The following is a description of a gene set: Genes having at least one occurrence of the motif NGGCTCYATCAYC in the regions spanning 4 kb centered on their transcription starting sites. This matches the transcription factor binding site V$ZID_01 (v7.4 TRANSFAC). studied in species Homo sapiens Human Gene Set: ZID_01, and this is the list of marker genes: PAMR1, ERF, CCDC85B, TRIML2, ZNF654, CNTN1, MBNL1, PRR34, FASTK, MIR17HG, PPP2R2B, PKIB, CAPNS1, SART3, MSTN, SERINC1, ITPR3, PLAG1, SMTNL2, RAPGEFL1, TMEM255A (NCBI Gene Id 55026, transmembrane protein 255A), TMEM145, HCN4, ATP2A2, SP4 (Sp4 transcription factor), MTMR11 (NCBI Gene Id 10903), UST, FAU, LRATD1, MEOX1, PTCHD1, TLX3, ZNF668, LRRC49, PLXNA3, NFYA, BCS1L, PA2G4, TP53BP1, TIAM1, PHLPP1, DOK7, MARCKS, MYO10, HMGB1, CNTLN, HOXA3, PLA2G2F, EVA1B (NCBI Gene Id 55194), PCF11, PGF, ERBB3, PSD, GDPD3, XK, SERPINI1, MYH6, PAFAH1B1, ISL1, PAX6 (paired box 6), ZCCHC14, FGFR1, APEX2, NT5C1B, ARHGAP44, GNL3LP1, SEMA6C, UBE2Z, AMOTL1, THAP10, COMMD10, TRAPPC3, FBXO24, PHTF1, SETBP1 (SET binding protein 1), HTR1B, ZNF287, SIAH1, NUFIP2, FBXL3, PAPPA, NGFR, DMD, SLC17A3, TPGS2, ZIC1, ATXN7L2, TAOK2, SUPT6H, TSC22D4, CCNYL1, RPS6KA4, TCF4 (transcription factor 4), PSMD8, HNRNPUL1, CMTM5, CEP95, ZKSCAN8, ADAM12, LRCH4, TNKS1BP1, FOXP1, MRPL49, SCRT2, BPIFB6, MECP2, POLG, TMUB1, RIN2, SECISBP2L, MTF1, KDM6A, ZNF513, CERS1, MPZL2, BICDL1, CCDC121, MSI2, ELK3, DHX30, H3C4, RBM26, GALNT17, MANEAL, ACTN3 (actinin alpha 3), CDK5R1, PLEKHA8, NELL2, SUPT16H, KCNE5, THSD4, CIPC, ZBTB33, TUG1, ACVR2A, WHRN, IRF2BPL, ZNF711, LBX1, SAT1, GABARAPL2, GGN, TSC22D3, MPP3 (NCBI Gene Id 4356), TPRN, NEURL1 (NCBI Gene Id 9148, neuralized E3 ubiquitin protein ligase 1), NLGN3, RNH1, GDF1, BCAM, STX1B, MACO1, SPAG8, AFF4, GPHB5, LIN28A, TRIM46, DNAJB5, DDR2, PRMT3, ODF2, ABTB2, ANXA9, DDX5, RAB2A, RBM15B, GFI1, THPO, H2BC7, C1QTNF6, HOXB9, RB1CC1 (NCBI Gene Id 9821), DCHS1, CHD4, DRG1, TMEFF1, H2AC7, CLEC4D, CDKL5, JMJD1C, PRELP, C12orf54 (NCBI Gene Id 121273), XIRP1, FAM83H, PIANP, MAB21L1, GRIK3, OARD1, CBLN4, CHCT1 (CHD1 helical C-terminal domain containing 1), BTK, DPF3, UBE2N, PLP1, ZIC4, MEIS2 (Meis homeobox 2), CACNG2, CTCF, EPB41, ZNF646, MRPL24, THBS1, GCNT3, SMDT1, MRPL40, FKBP14, HOXB8, PHF8, PRSS36, OTUD7B, ESRRG, ENPP1, KCNK10, TLN1, HR, KRTCAP2, ISCU, SLC35A1, TLX1, ANAPC15, BEND6, SKIL, ADSS2, PHOSPHO1, PNCK, RSKR, DCLK1, DACH1, SNW1, CHRD, DDIT4L, AKAP1, B4GALT2, CSDE1, MTMR10, ANKH, VCAN, CREB3, HIRA, CASZ1, PPTC7, CHD2, WNT6, XRCC6, TAGLN3, METRN, AP2M1, SESN3, CDC25A, BAHD1, KPNA4, PIPOX, CHMP4B, STXBP6 (NCBI Gene Id 29091), SPINK5 (NCBI Gene Id 50962), FIS1, MAP4K5, BCAR3, SNX12, PDCD10, RBPJ, ZDHHC24, HMBOX1, SDF2, ZEB1, YTHDC1, LTBP1, GPR173, CA9